Given this list of marker genes Osbpl11, Ube2v2, Ccdc73, Seh1l, Sgpp1, Abhd13, Smad5, Ammecr1, Zbtb1, Megf9, Plekhg3, Riok2, C1qtnf3, Phf20l1, Trabd, Tdrp, Acvr2b, Zfp1008, Glcci1, Fbxl2, Gimap8, Senp7, Dennd1b, Erlin2, Itgb6, Pde1c, Ap4e1, Cacna1d, Msantd3, Fam118a, Magi1, Cadm3, Gm7694, Edem3, Hbp1, Zfp953, Bzw2, Tacc1, Arnt, Elmod2, Ms4a2, Tmem170b, Atp2a2, Ccdc149, Kcnd2, Atl1, Ppm1e, Hmgn5, Ccnt2, En1, Sox12, Wnt3, Raph1, Slc9a9, Mat2b, Fli1, Nr2e3, Ogt, Rcor1, Kpnb1, Cdca7l, here is a description of the gene set: Mouse Gene Set: MIR_6912_3P studied in species Mus musculus Genes predicted to be targets of miRBase v22 microRNA mmu_miR_6912_3p in miRDB v6.0 with MirTarget v4 prediction scores > 80 (high confidence targets). from publication Chen Y, Wang X (PMID 31504780)